Given this list of marker genes RCC2, EXOSC5, CBR1, TREML1, LSP1, EFR3A, PGM2, FH, CAMK1, NDUFAF4, SPP1, TMA16, PSMA5, ATP1B1, ALG5 (NCBI Gene Id 29880), MRPL27, MRPL15, RMDN3, CA2, LPL, PPARGC1B, AVPI1, TRIAP1, SRD5A3, PRDX1, ATP5MJ, SPOCD1, ATP5F1A, NETO2, LARP4, ALDH1A2, LSM12, EPS8, MYOF (myoferlin), SRPRB, MAGOHB (NCBI Gene Id 55110), CHCHD10, RSC1A1, SNX5, FASTKD1, SERPINE1, PDHA1, FASTKD2, SLC25A13, RAB7B, IL1R2, FABP4, CHCHD4, AGPS, NUDCD2, CD52, UCHL3, PRMT3, TIMM21, TREM2, CLUH, GCLC, SPRY2, RBX1, COL8A2, NUDT19, MTERF3, PTPMT1, SETD7 (SET domain containing 7, histone lysine methyltransferase), A2M, ALG14, COX5B, GTF2E1, FAIM, NUDT9, GLUD1, MRPS35, RAPH1, PI4K2A, C17orf58, METTL1, NIPSNAP2, POLR1C, RPS6KA2, GATD3, FN1, DCTD, TMED10, ZZZ3, GAL, CD9, ASPH, EEF1E1, DOCK3, MTPAP, NDUFA4, CD1E, NDUFS3, LIPA, CHCHD2, CD1B, MDFIC, SLC25A43, CDK5, WDR74, TIMM17A, NUDT15, PET117, FDXACB1, ARHGAP10, ATP5MC3, ZNF146, S100A1, TSC22D1, SDHB, HSPA9, IQGAP2, NANP, ALDH3A2, MDH1, ACOX3, SP2-AS1 (NCBI Gene Id 100506325), MAIP1, TAF9, AIRIM, NCBP2, PTRH2, FABP5, GREM1, RABGGTB, GEMIN6, NRP2, NMB (neuromedin B), GALE, LRRC58, FRMD4B, SLC29A3, GFM1, CYCS, DCSTAMP, CCDC43, CANX (NCBI Gene Id 821), PTP4A1, MRPS28, GUF1, PIGW, UBE2V2, MICOS10, NUDT12, DHRS11, MTIF2, GGCT, RPE, TRUB2, SLC17A9, SLC35B1, ME1, C8orf33, BLOC1S2, LHFPL2, SUCLA2, ME3, GRSF1, ATP5MC1, CHEK2, FAM162A, CHD9, LGALS9, MTFP1, COX10, DAG1, FDX2, DPAGT1, MRPS7, TMEM70, FNTB, NDC1, COX7B, SBF2-AS1, GLRX3, SLC50A1, KCNJ5-AS1, POLD1, CSTF3, HNRNPA3 (heterogeneous nuclear ribonucleoprotein A3), SLC25A5, UTP18, BEND3, LIAS, CD84, CD109, RAP1GDS1, FUCA2, RAB40B, GALM, COX18, ECHDC1 (ethylmalonyl-CoA decarboxylase 1), ZW10, C1orf198, GPC4 (glypican 4), E2F6, MRPL4, NDRG2 (NCBI Gene Id 57447), GEM, MCRIP2, here is a description of the gene set: Cytokine-activated STAT proteins dimerize and bind to high-affinity motifs, and N-terminal domain-mediated oligomerization of dimers allows tetramer formation and binding to low-affinity tandem motifs, but the functions of dimers versus tetramers are unknown. We generated Stat5a and Stat5b double knock-in (DKI) N-domain mutant mice that form dimers but not tetramers, identified cytokine-regulated genes whose expression required STAT5 tetramers, and defined consensus motifs for dimers versus tetramers. Whereas Stat5- deficient mice exhibited perinatal lethality, DKI mice were viable, indicating that STAT5 dimers were sufficient for survival. Nevertheless, STAT5 DKI mice had fewer CD4+CD25+ T cells, NK cells, and CD8+ T cells, with impaired cytokine-induced proliferation and homeostatic proliferation of CD8+ T cells. DKI CD8+ T cell proliferation following viral infection was diminished and DKI Treg cells did not efficiently control colitis. Thus, tetramerization of STAT5 is dispensable for survival but is critical for cytokine responses and normal immune function. from publication Lin JX, Li P, Liu D, Jin HT, He J, Ata Ur Rasheed M, Rochman Y, Wang L, Cui K, Liu C, Kelsall BL, Ahmed R, Leonard WJ (PMID 22520852) Genes down-regulated in STAT5 double knock-in T cells: control versus IL2 stimulation for 6h. species: Homo sapiens Human Gene Set: GSE36888_UNTREATED_VS_IL2_TREATED_STAT5_AB_KNOCKIN_TCELL_6H_DN